The following is a description of a gene set: part of: Defects of contact activation system and kallikrein-kinin system  Alzheimer’s disease (AD) is characterized by the accumulation and aggregation of amyloid beta (Aβ) peptides, such as APP(672–711) and APP(672–713), which primarily accumulate in the brain as plaques and are also detectable in the plasma of AD patients. Aggregated Aβ peptides provide a negatively charged surface that facilitates the binding of factor XII (FXII) (Joseph K et al., 1999; Bergamaschini L et al., 2001; Zamolodchikov D et al., 2015). Surface-bound FXII is converted to its active form, FXIIa, which subsequently activates plasma prekallikrein, converting it into the active enzyme kallikrein. Kallikrein, in turn, enzymatically cleaves high molecular-weight kininogen (HMWK), leading to the release of the proinflammatory mediator bradykinin. FXIIa also exhibits procoagulant activity by activating factor XI (FXI) (Schmaier AH, 2016a,b).<p>Studies have shown that Aβ aggregates enhance FXII activation both in vitro and in vivo (Shibayama Y et al., 1999; Joseph K et al., 1999; Bergamaschini L et al., 2001; Zamolodchikov D et al., 2015, 2016; Chen ZL et al., 2019; reviewed by Kaplan AP et al., 2024). Therapeutic antibodies, such as lecanemab, target Aβ plaques blocking this activation (Chen ZL et al., 2023; Johannesson M et al., 2024). Elevated kallikrein activity and increased levels of cleaved HMWK in the cerebrospinal fluid, along with higher plasma concentrations of FXIIa, cleaved HMWK, and bradykinin, have been observed in AD patients and correlated with AD pathology and cognitive impairment (Bergamaschini L et al., 1998; Yamamoto-Imoto H et al., 2018; Singh PK et al., 2020). In post-mortem studies, Aβ plaques from the brain tissue of AD patients were found to contain both FXII and bradykinin (Yasuhara O et al., 1994; Singh PK et al., 2020). A similar activation of the FXII-induced kallikrein–kinin system has been observed in Alzheimer’s mouse models and in wild-type mice injected with Aβ aggregates (Zamolodchikov D et al., 2015; Chen ZL et al., 2017; reviewed by Kaplan AP et al., 2024). Additionally, Alzheimer’s patients exhibit increased plasma levels of FXI, which contribute to FXII-induced thrombin formation (Zamolodchikov D et al., 2016; Begic E et al., 2020; Schmaier AH, 2016a,b). These findings suggest that interactions between Aβ aggregates and FXII may contribute to vascular dysfunction, prothrombotic state, and neuroinflammation associated with Alzheimer’s disease pathology. studied in species Homo sapiens Reactome Pathway: Aggregated β-amyloid induces FXII autocatalysis, and this is the list of marker genes: F12, APP